Given this list of marker genes NLRP3, ABCD1, CLEC4A, NAV3, MIR215, MIR6869, INHBA, GPNMB, WNT11, C5AR2, ANXA4, MIR488 (NCBI Gene Id 574441), LAPTM4B, FOXJ1, TRIB2, MERTK, CYLD, MIR15B, MIR125A, MIR181A2, RNF128, DDX56, TLR4 (NCBI Gene Id 7099), MIR222, TNFSF4, XAF1, YY1, MIR107, ATG12, CD200, KLHL22, GATA3, NCKAP1L, MIR136, IL1RL1, MIR372, IDO1, INPP5D, SRGN, TGFB1, MIR206, ILRUN, RELA, TWSG1, CARD17P, RELB, PPARA, CD33, PPP1R11, MAPKBP1, MIR194-1, QKI, SSC5D (scavenger receptor cysteine rich family member with 5 domains), MIR320A, BTK, CX3CL1, MIR185, IL27RA, JAK2, PDCD4 (programmed cell death 4), GHRL, INHBB, THBS1, HSF1, CRYBA1, ZFP36, EXTL3, ELF4, PYDC2, TNF, NLRP6, MIR181D, MIR128-1, CR1 (complement C3b/C4b receptor 1 (Knops blood group)), RNF216, KLF4 (KLF transcription factor 4), MIR129-1, IL23R, FBLN1, MIR132, VSIG4, MIR200C, MIR195, PSG9, TNFRSF21, HOMER2 (NCBI Gene Id 9455), NFKBIL1, LILRB4, IFNG, NDFIP1, MIR214, ABCD2, MIR16-1, ERRFI1, SLC2A10, BCL3, EPHA2, MIR105-1, MIR192, NFKB1, LEF1, MIR877, IL1R2, PTPN6, MC1R, PDCD1LG2, SPINK7, RNF125, TIGIT, HOMER3, MIRLET7F1, MIRLET7C, C1QBP, LGALS9C, LAPTM5, FFAR1, PTGER4, IL4, MIR181C, GPR174, MIR106A, LGALS9 (NCBI Gene Id 90793), PYCARD, REL, INHA, ZNF683, NMI, TLR6, MIR302A, PGLYRP1, PGLYRP3, MIR766, EPHB2, TREM2, LAG3, PRNP, MIR101-1, CD24 (CD24 molecule), MIR874, MIR28, MIR34A (microRNA 34a), SFTPD, TBX21, NLRC3, APOD (NCBI Gene Id 347), LBP, MIR383, MIR657, MAP2K5, MIR142, HMOX1, TGFB3, FCGR2B, LGALS9B, HDAC3, PTPN22, MIR197, MIR708, ZFPM1, TYROBP, IL23A, MIR373, OAS1, LILRA4, MIR217, CSK, MIR590, GHSR, HLA-F, LTF, MIR146A, DDIT3, SERPINB1, ARG1, DLL1, FXR1, CACTIN (NCBI Gene Id 58536), IL37, IKBKB, MIR155, IL36RN, UFD1, MIR24-1, BANF1, MIR20B, MIR29B1, CARD18, MIR302C, FGFR1 (fibroblast growth factor receptor 1), RGCC, IL33, CD2AP, VSIR, CPTP, ITCH, NDRG2, ADCY7, PRKCA, HMGB1 (NCBI Gene Id 3146), RAD21, SIGLEC1, IL12B, GIT1, MIR147A, SLC11A1, NPTN, CD96, F2RL1 (NCBI Gene Id 7901), PTPRS, DHX58, MIR920, RAC1, IRGM, GPATCH3, MIR135A1, CARD16, MIR93, GBA1, MIR204, JAK3, ATG9A, MIR199A1, TNFAIP3, PIBF1, PYDC1, MIR19B1, BPI, TSKU, CD34, FFAR4, PGLYRP2, C1QTNF3, MORC3, CIDEA, CCR7 (NCBI Gene Id 1236), CD274, ORM1, AGER, F2, MIR26A1, FURIN, APOA2, TSPO, PRKACA, ZC3H12A (NCBI Gene Id 80149), MEFV, IFNB1, MIR106B, GBP1, SELENOS, APOA1, MIR411, SOCS5, MIR520G, NLRP7, RABGEF1 (RAB guanine nucleotide exchange factor 1), NR1H4, HLA-DRB1, SARS1, TUSC2, MIR26B, XCL1, MIR520B, MIR140, EPX, NFKBIA, MUL1, MIR520C, PML, HDAC7, CARD8, ATG5, CASP3, NMB, MIR134, OAS3, TRAF3IP1, CX3CR1, LRRC32 (NCBI Gene Id 2615), MIR27B (microRNA 27b), LGR4, GAS6, CUEDC2, TRIM27, ANXA1, NLRX1, MIR338, TIA1, BST2, DICER1, CEACAM1, MIR98, BANK1, MIR17, STAT3, MIR19A, MIR31 (NCBI Gene Id 407035), ANGPT1 (angiopoietin 1), SIGIRR, NLRP2B, N4BP1, OTUD5, CD83, POMC, ADIPOQ, SLAMF1, ELANE, HFE, IGF1, EZH2, GATA6 (GATA binding protein 6), IL13, MIR149, GSTP1, MIR125B1, LILRA5, ARRB2, MIR203A, NLRP12, MIR210, MIR506, PTPRC, MIR205, ASB1, MIR520H, CMKLR1, MIR146B, ERBIN, APPL2, TGFB2, ACP5, ARG2, IFNL1, PRG2, IL6R, MIR152, ATP2B1 (NCBI Gene Id 490), FN1, TRAIP, OTUD7B, MIR365A, AXL, RPS6KA4, IRAK3, TICAM2 (TIR domain containing adaptor molecule 2), CHID1, CD200R1, PLA2G10, GBP7, MIR145, NPLOC4, RBX1, FOXP3, PPM1B, MIR200B, MIR15A, IL20RB, SIRPA, SYT11, ARRB1, GPR18, BTN2A2, KLF2, MIR221, HDAC9, EZR (NCBI Gene Id 7430), MACIR, TWIST1, MIR504, IL12A, NMBR, SCGB1A1, IL10, RPS6KA5, PTPN11, MIR20A, DEFB114, SMAD7, KAT5, HAVCR2, AKAP8, MIR21 (NCBI Gene Id 406991), CHRNA7, ACOD1, RARA, MIR378A, KAT8, MIR130A, TLR8, MIR361, HGF, IL6, MIR935, IFNA2, LILRB1, BCL6, CUL3, CD84 (CD84 molecule), MIR302D, MIR100, here is a description of the gene set: Human Gene Set: GOBP_NEGATIVE_REGULATION_OF_CYTOKINE_PRODUCTION studied in species Homo sapiens Any process that stops, prevents, or reduces the rate of production of a cytokine.